The following is a description of a gene set: studied in species Homo sapiens Agenesis of maxillary incisor Human Gene Set: HP_AGENESIS_OF_MAXILLARY_INCISOR, and this is the list of marker genes: NAA10 (N-alpha-acetyltransferase 10, NatA catalytic subunit), ERCC3 (ERCC excision repair 3, TFIIH core complex helicase subunit), TGFA, WNT10B, LRP6, SUMO1, WNT10A, AXIN2, IRF6 (interferon regulatory factor 6), BLM, FGFR1, B3GLCT, ADAMTS15, BCOR, MSX1, EDARADD, PAX9, EDA, RIPK4